Given this list of marker genes Pik3cd, Gdf2, Flt4, Ccl2, Vip, Egf, Dicer1, Hspg2, Zfp580, Sirt1, Hmgb2, Wnt2, Arg1 (arginase, liver), Akt3 (NCBI Gene Id 98462), Apln, Bmp4, Mtor, Ghsr, Sirt6, Egr3, Ccr3, Jun, Prkd1, Pdcd6, Tgfbr1, Ang4, Ccl11, Itga4, Prox1, Cxcl12, Ppp1r16b, Hmgb1, Cdh13, Mydgf, Col18a1, Vegfb, Agtr1b, Ghrl, Ccl24, Ang, Rictor, Fgf2, Fgf7, Igf2, Pdpk1, Emc10, Itgb3, Pdcl3, Aplnr, F3, Akt1, Nrarp, Dysf, Pgf, Vegfa, Pold4, Prok1, Ecm1, Nras, Cav2, Adora2b, Rptor, Fgfr1, Mdk, Sema5a, Bmp6, Ccl26, Prkd2, Nr4a1, Agtr1a (NCBI Gene Id 72294), Lrg1, Htr2b, Nf1, Stat3, Wnt5a, Plcg1, Egfl7, Plxnb3, Jcad, Acvrl1, Adam17 (NCBI Gene Id 236174), Ang2, Igf1, Il10, Vash2, Pdgfb, Fgfbp1, Scg2, Hmox1, Aggf1, Cyba, Ang6, Sp1, Gata2, Apela, Cav1, Kdr, Fgf10, Thbs4, Ang5 (NCBI Gene Id 503844), Fgfr3, Prkca, Stat5a, here is a description of the gene set: species: Mus musculus Any process that activates or increases the rate or extent of endothelial cell proliferation. Mouse Gene Set: GOBP_POSITIVE_REGULATION_OF_ENDOTHELIAL_CELL_PROLIFERATION